Given this list of marker genes SLC27A2, USP30, MIEF2, SYT7, SOD1, VWA8, MVK, PJVK, SCP2, AOC1 (NCBI Gene Id 26), ABCD4, ALDH3A2, SLC25A17, FIS1, TYSND1, ACAA1, PEX5L, MAVS, CNOT1, FNDC5, TMEM135, HMGCL, PEX6, ACOX2, MGST1, KCNIP4, PXMP2, ACOT2, ACOT8, C6orf226, TKT, EHHADH, PEX14, IDH2 (NCBI Gene Id 3418), NUDT17, ACOXL, PEX11A, ACAD11, PEX16, FAR2, SERHL2, ISOC1, HMGCR, PEX12, HACL1, ACSL4, PEX1, PAOX, GDAP1, IDI1, DEPP1, RIDA, GBF1, FABP1, NUDT7, CCDC33, ABCD2, MARF1, PEX5, SZT2, RAB8B, PTGR3, NBR1 (NBR1 autophagy cargo receptor), LACC1, MPV17L, PEX26, IDI2, AGPS, PEX3, IMPDH2, PMVK, HSD17B4, TMEM35A, ABCD3, MTARC2, CD33, MVD, TTC1, ABCD1, TRIM37, NUDT12, PEX13, MPV17, DNM1L, ACBD5 (acyl-CoA binding domain containing 5), DDO, ACSL3, EPHX2, ECH1, ATAD1, CRYM, VIM, CRAT, DHRS4L2, GNPAT, URAD, DHRS4, DECR2, PNPLA8, ACOX3, CROT, POMC, MUL1, PLAAT3, PXT1, MLYCD, GSTK1, PIK3C3, IDH1, ECI2, XDH, ACSL1, AMACR, NUDT19, MFF, MIEF1, DHRS4L1, PEX10, DAO, PEX11B, FDPS, MAP2K2, GRHPR, PIPOX, PXMP4, MYO5A, IDE, NOS2, PRDX5, HSDL2 (NCBI Gene Id 84263), CAT, ACSL6, AGXT, HAO2, PEX19, LONP2 (lon peptidase 2, peroxisomal), ACOT4, STING1, ACOX1, PHYH, ATM, DHRS7B, PEX2, PECR, ACOT6, HAO1, MGAT4A, PEX7, BAAT, FAR1, PEX11G, here is a description of the gene set: Cytoplasmic organelles, spherical or oval in shape, that are bounded by a single membrane and contain oxidative enzymes, especially those utilizing hydrogen peroxide (H2O2). Human Gene Set: GOCC_MICROBODY species: Homo sapiens